Given this list of marker genes CTC1, BMPR1A, PTEN, TEK, APC, STK11, here is a description of the gene set: studied in species Homo sapiens Bleeding from the intestines. Intestinal bleeding Human Gene Set: HP_INTESTINAL_BLEEDING